The following is a description of a gene set: Human Gene Set: REACTOME_METABOLISM_OF_POLYAMINES Metabolism of polyamines species: Homo sapiens, and this is the list of marker genes: PSMD6, SRM, PSMA4, PSMA5, PSMD3 (NCBI Gene Id 94019), AMD1, SMOX, PSMD8, SMS, PSMC2, PSMD1, SAT1, PSMA2, PSMB5, PSMB2, AZIN2, SEM1, PSMD12, PAOX, OAZ1, PSMD14, PSMB7, PSMC5, PSMA7, NQO1, PSMC4, PSMD13, AZIN1, PSMA3, PSMB4, PSMD11, PSMB6, PSMD2, PSMD7, AGMAT, ADRM1, PSMC6, OAZ2, ODC1 (NCBI Gene Id 4953), PSMA1 (proteasome 20S subunit alpha 1), PSMB3, PSMA6, PSMC1, OAZ3, PSMB1, PSMC3